Given this list of marker genes EPB41L3, MYRF, AKT2, CLU, PRX, ABCD2, FA2H, PALS1, DEGS1, PLEC, NDRG1, CXCR4, SOD1, AKT1 (NCBI Gene Id 207), ABCD1, MIR26A1, SH3TC2, PTEN, here is a description of the gene set: studied in species Homo sapiens Human Gene Set: GOBP_MYELIN_MAINTENANCE The process of preserving the structure and function of mature myelin. This includes maintaining the compact structure of myelin necessary for its electrical insulating characteristics as well as the structure of non-compact regions such as Schmidt-Lantermann clefts and paranodal loops. This does not include processes responsible for maintaining the nodes of Ranvier, which are not part of the myelin sheath.